Given this list of marker genes Dhfr, Dctd, Dpyd, Dpys, Upp1, Nme3, Tymp, Nme1, Nt5c3, Shmt1, Dut, Nme2, Tyms, Shmt2, Nt5c, Upb1, here is a description of the gene set: Mouse Gene Set: GOBP_DTMP_METABOLIC_PROCESS species: Mus musculus The chemical reactions and pathways involving dTMP, deoxyribosylthymine monophosphate (2'-deoxyribosylthymine 5'-phosphate).